Given this list of marker genes TASP1, S1PR1, LYST, RPL37, PRSS12, KLRD1, PIK3CB, ADGRB1, RDH5, BLTP3B, PRR13, PSEN2, HLA-E, MAP3K7, MAP7, IDUA, AKNA, HLA-B, NANOS1, EMCN, NHERF1 (NCBI Gene Id 9368), DPH1, ANTXR2, KCTD17, TNFRSF13C, APOBEC3B, LY6E, TEC, SLC7A1, TTC39B, CISD3, PDK1, PLCB3, BCLAF1, RPL35, RCN1, SLC12A9, SLC37A2, RUNDC3B, CD200R1L, OXLD1, CRBN (NCBI Gene Id 51185), ITGA6, CASP4, TDP2, PRXL2C, QPRT, RCCD1, AFG2B, AVPI1, CREB3L2, LGR4, RPL36A, LANCL3, DDX3Y, RBM43, NOTCH2, PPP1R18, ATF7IP, LRIG1, TNFSF14, MYO15A, MS4A1, GCNT1, DMRTA1, LATS2, CRTAM, TMEM38B, RSAD1 (NCBI Gene Id 55316), RPGRIP1 (RPGR interacting protein 1), CXCR3, AASDH, RPS9, ALDOA, RAB6B, GBP4, CALHM6 (calcium homeostasis modulator family member 6), PEX11A, CST7, ZBTB40, DNMT3B, ZBTB42, S100A4, ODC1, BTG1, AFP, PLAAT3, H2AB2, PTGIS, OSGIN1, ABTB3, LDLR, DSTYK, RPS16, GPM6B, GMPPA, ATP6V1D, PINK1, SLC15A2, IFNG, NUAK2, SH3BP5, LAMC2, CBX7, TRIM11, EFHD2, CASP1, MYH11, CYP4V2, SPNS3, UTY, ITGB1, SLC1A5, ZSCAN12, PTGR3, STK39, OAS1, NUDT6, CCDC198, RRP8, FAM210B, DAPK1, MFF, DMBT1, ARHGAP5, RIC8A, ATXN1, BANK1, CEBPB, XDH, BICRAL, MIF4GD, GPATCH4, PNPLA6, GPC1, SOCS3, FCMR, C2orf74, IRAK3, ZFP36L1, GNS, LINC01160, CKB, TRIM2, SERPINB9, SCD, CDC42EP3, SIPA1L2, HGSNAT, RGS1, CHRNA1, RRAS, BCL2A1, PTGES2, INSIG1, ADCY10, APP, RNF144A, PDCD11, PBXIP1, FMO5, EID2, CUBN, SLC52A3, DNAJB2, KDM5D, CCL5, ENPP1, TRMT61A, S100A6, ADAP2, DGKE, RGMB, CCDC160, NKG7, RAD23A, ACADL, TMEM229A, TIGAR (NCBI Gene Id 57199), TPD52, MBLAC2, HYCC1, IL2, CYP2S1, LRRC75B, FANCF, TOX4, KIAA0232, DAPL1, PLSCR1, GNPTG, CAMK2B (NCBI Gene Id 816), CTLA4, USP36, IL18R1, TMEM31, ACOT13, SULT4A1, METTL1, here is a description of the gene set: Human Gene Set: GSE7852_LN_VS_THYMUS_TCONV_UP Comparisons of global gene-expression profiles revealed a greater distinction between CD4+ Treg cells and CD4+ conventional (Tconv) T cells residing in abdominal (epidydimal) fat versus in more standard locations such as the spleen, thymus and LN. from publication Feuerer M, Herrero L, Cipolletta D, Naaz A, Wong J, Nayer A, Lee J, Goldfine AB, Benoist C, Shoelson S, Mathis D (PMID 19633656) Genes up-regulated in comparison of lymph node conventional T cells versus thymus conventional T cells. species: Homo sapiens